The following is a description of a gene set: species: Homo sapiens from publication Schaefer CF, Anthony K, Krupa S, Buchoff J, Day M, Hannay T, Buetow KH (PMID 18832364) Human Gene Set: PID_PTP1B_PATHWAY Signaling events mediated by PTP1B, and this is the list of marker genes: TXN, INS, SOCS3, BCAR1 (NCBI Gene Id 9564), LYN, FCGR2A, LAT, IRS1, PIK3CA, STAT3, CSF1R, CAPN1, YES1, CRK, TRPV6, LEP, JAK2, CSK, SPRY2, LCK, INSR, CDH2, PDGFRB, PDGFB, LEPR, PTPN1, ITGB3, STAT5B (NCBI Gene Id 6777), TYK2, YBX1, FYN, FGR (FGR proto-oncogene, Src family tyrosine kinase), DOK1, EGF, BLK, PRL, STAT5A, CSN2, EGFR, NOX4, RHOA, CAV1, PRLR, CSF1, GRB2, FER, SHC1, PIK3R1, HCK, ITGA2B, SRC, AKT1